The following is a description of a gene set: Any process that modulates the frequency, rate or extent of tight junction assembly. studied in species Homo sapiens Human Gene Set: GOBP_REGULATION_OF_BICELLULAR_TIGHT_JUNCTION_ASSEMBLY, and this is the list of marker genes: RAC1, MYO1C, CLDN5, ROCK2, PRKACA, NPHP4, TJP1 (tight junction protein 1), RPS6, IKBKB, F11R (NCBI Gene Id 50848), IL17A, NPHP1, CLDN1, ROCK1, ACVRL1, EPHA2, MIR105-1, DSG3, GPBAR1, GDF2, TNF, MIR142, FZD5, SNAI2, PRKCH, SNAI1